Given this list of marker genes SEC14L1, LCP2, RPL12P12, CEBPD (NCBI Gene Id 1052), ZFAS1, NBEAL2, NCF1C, CYTH1, TMEM154, RNA5SP207, ALDH16A1, COX5B, DOK3, CCNI (cyclin I), S100P, PDLIM7, FOS, PLPPR2, SOCS3, SAT1, CDC42SE1, PREX1 (NCBI Gene Id 57580), PELATON, MIDN, SELL, CTSS, PGD, FGD4, ORAI2, STK38, ASPH, KMT2E-AS1, CLEC7A (NCBI Gene Id 64581), STX3, PTGES3P1, PLXNC1, MAPKAPK2, MZT2B, PER1, PFKFB2, BCL3 (NCBI Gene Id 602), TMEM259, GNB2, MYL6, MRTFA, SOD2, SLA (NCBI Gene Id 6503), MARCHF6, ACTN1 (actinin alpha 1), PELI1, ABHD5, KY, SLC45A4, KDM6B, TLR2, IFITM3 (NCBI Gene Id 10410), FTLP3, VNN2, BBLN, PLAUR (NCBI Gene Id 5329), ZNF638, KDELR1, YPEL3, WASH7P, LUCAT1, SLC6A6, SLC16A3, BCL2A1, CLEC4E, CCDC88B, UBE4A, ATG2A (autophagy related 2A), MEGF9, TLE3 (TLE family member 3, transcriptional corepressor), TMA7, ENTPD1, RPL3P7, ADM, HLX, ZBTB7A, NCF2, MEFV, TLR6, TREM1, FKBP8, H3P6 (NCBI Gene Id 440926), FCGR3B, RNF149, TMEM91, FPR1, DDX17, PSMA6, ANKRD44, RNF213, ANPEP, BRI3, ADGRG3, ARHGEF40, LAMTOR4, EMP3, RTN3, ATG16L2, XPO6, FFAR2, CYP4F3, JUNB, KLF2, CKAP4, CTDNEP1, COX7A2, CDK2AP2, SPI1, G0S2, TSTD1, NCF1B, ADAM8, FTH1P7, APOBEC3A, LPAR2, RGS2, IGF1R, CR1, PPP3CA, BEST1, HLA-B, CNPPD1, CSF3R, FAM107B, MSL1, IL1R2, TNFRSF1A, CEBPZ, FTH1, YJU2B, CALM3, POM121, FAM89B, LIMK2, NOP10, PLIN5, TMUB1, RPS19BP1, IL17RA, NAMPTP1, DNAH17, UQCRHL, IRS2, TYROBP, ARHGAP1, RNA5SP151, MAX, ACSL1, GIGYF1, EPC1, CATIP, CICP27, GLT1D1, WAS, P2RY13, MHENCR, NAMPT, ARHGEF1, FTH1P8, PFKFB3 (6-phosphofructo-2-kinase/fructose-2,6-biphosphatase 3), NTNG2, S100A12, MXD1, PLK3, MME, NFAM1, NIBAN1, H3-3A, CXCR2, MNDA, CPD, CA4, CHI3L1, LRP10, DHX34, TKT, MX2 (NCBI Gene Id 4600), S100A9, COX6B1, ALOX5AP, MARCKS, MMP25, ARHGAP9, RGS18, NCF1, NDUFB1, RASGRP4, IFRD1, ELAPOR1, PPP1R35, C5AR2, GNAI2, VAMP2, SNHG3, RAB5C, FGD3 (FYVE, RhoGEF and PH domain containing 3), IL18RAP, COX8A, S100A11, RNF145, NPIPB13, NFE2, MKNK2, RUBCNL (rubicon like autophagy enhancer), MMP9, SLC35E2B, UNC13D, RPS19P3 (NCBI Gene Id 731572), EMB, R3HDM4 (NCBI Gene Id 91300), PI4KA, CMTM2, RPSAP15 (NCBI Gene Id 220885), CWC15, RPL7AP30, ULK1, LRRK2, DGAT2, PCBP1-AS1 (PCBP1 antisense RNA 1), HCLS1 (hematopoietic cell-specific Lyn substrate 1), MCL1, BASP1, GCA, RALB, SPTAN1, JTB, DENND3, LRG1, SLC2A3, SUPT16H, NDUFA1, HAL, SLC25A37, NCF4, FTH1P10, RESF1, S100A6, S100A8, SMCHD1, IRAK3, SAMSN1, BCL6, C5AR1, NICOL1, CEACAM3, BRD4, IFITM2, NEAT1, ARG1, B4GALT1, NDUFB3, AMPD2, TNFRSF10C, MYO1F, TNFAIP3, DOCK11, MAST3, PHC2, WDFY3, IGF2R, JAML, CDK11B, ATP6V1F, NAP1L4, CASP2, HNRNPUL1, CCNJL, JUND, CSNK1D, REPS2, KCNJ15, TWF2, CDA, C16orf54, CHTOP, BST1, DAPK2, ARRB2, CRISPLD2, F8A1, SMAP2, IL1RAP, FKBP5, FTH1P20, CHST15, PAN3, RNF24, TMSB4XP4 (TMSB4X pseudogene 4), DUSP1, TMCC3, FCGR2A, CSTB, STEAP4, DYSF, SIRPB1, RBM47, TLR4, POU2F2, NBPF10, PYGL, CORO1A, WASH3P, PROK2, ZDHHC18, PGGHG, CREB5, CXCL8, RASSF3, NDUFS6 (NADH:ubiquinone oxidoreductase subunit S6), CEBPB, FTH1P3, MTND5P32, ZNF518A, FTL, PKM, G6PD, SUN2, SIPA1L2, ATP5F1E, R3HDM2, FPR2, IL2RG, B4GALT5, ABTB1, PADI2 (NCBI Gene Id 11240), CTSD, BTG2, VSIR, MGRN1, TOP1, SLC11A1, TP53INP2, METTL26, UBALD2, WASHC1, VNN3P, ALPL, LAMTOR2, AQP9, MAP1LC3B2, EIF4EBP2, PHOSPHO1, MSRB1, ITGAX, C4orf3, PRR13, ARPC4, PTGS2, TBL1X, SORL1, CLEC4D, TRIB1, HERC1, VASP, RBMS1P1, CXCR1, TAPBP, SELENOK, TXNL4A (NCBI Gene Id 10907), PGLYRP1, CIRBP, SRGN, here is a description of the gene set: species: Homo sapiens from publication Travaglini KJ, Nabhan AN, Penland L, Sinha R, Gillich A, Sit RV, Chang S, Conley SD, Mori Y, Seita J, Berry GJ, Shrager JB, Metzger RJ, Kuo CS, Neff N, Weissman IL, Quake SR, Krasnow MA (PMID 33208946) Human Gene Set: TRAVAGLINI_LUNG_NEUTROPHIL_CELL